Given this list of marker genes ACAN, LZTR1, H19, SON, LMNA, NXN, APC, DHCR24, NF1, BRAF, USP7, FH, RIT1, PCGF2, TNFRSF11B, DOCK3, CUL4B, AXIN1, POLE, PTDSS1, TONSL, SERPINH1, PLAG1, KRAS, AHDC1, VPS35L, IHH, ZFX, MRAS, GRB10, BGN, DLK1, POLR3A, NONO, DPH1, ZMPSTE24, SOX9, SNX14, PPP1CB, CCDC22, APC2, INPPL1, POP1, DPH2, SATB2, MED12, SHOC2, CEP120, XYLT1, FGD1, POLR1A, LBR, EIF4A2, IGF2, MITF, OBSL1, ACER3, USP9X, ITCH, IFT81, MEG3, RTL1, HMGA2, TRIP11, CDKN1C, THRA, LAMA5, here is a description of the gene set: Relative macrocephaly Human Gene Set: HP_RELATIVE_MACROCEPHALY species: Homo sapiens A relatively mild degree of macrocephaly in which the head circumference is not above two standard deviations from the mean, but appears dysproportionately large when other factors such as body stature are taken into account.